Given this list of marker genes ASCC2, ASCC1, ALKBH2, MGMT, ASCC3, ALKBH3, ALKBH5, FTO, here is a description of the gene set: species: Homo sapiens Human Gene Set: REACTOME_DNA_DAMAGE_REVERSAL DNA Damage Reversal